Given this list of marker genes Ptprc, Hoxb4, Lipa, Ctc1, Sbds, Fancb, Lrp5, Mir188, Asxl1, Bmncr, Trp53, Lrrc17, here is a description of the gene set: The process whose specific outcome is the progression of the bone marrow over time, from its formation to the mature structure. species: Mus musculus Mouse Gene Set: GOBP_BONE_MARROW_DEVELOPMENT